The following is a description of a gene set: Electron transport chain Mouse Gene Set: WP_ELECTRON_TRANSPORT_CHAIN species: Mus musculus, and this is the list of marker genes: Uqcrq, mt-Co1, Cox6c (cytochrome c oxidase subunit 6C), Ndufb10, mt-Nd2, Ndufa6, Atp5f1c, mt-Atp8, Ndufb5, Ndufa9, Sdha, Ndufs1, Ndufa8, mt-Nd3, Uqcr10, Ucp1 (NCBI Gene Id 22227), Ndufs5, Ndufb3, mt-Nd4l, Ndufs7, Cox6a2, Atp5mf, Ndufs2, Atp5mc2, Atp5mc3, Ndufa7, Ndufv2, Uqcrc2, Cox5b, Ndufb9, Ndufb4c, Cox8a, mt-Co2, Cox6a1, Ndufb2, Uqcrc1 (NCBI Gene Id 66186), Ndufab1, Uqcrh, Atp5pb, Ndufc1, mt-Nd1, Cox7a2, Ndufs4, Slc25a27, mt-Atp6 (mitochondrially encoded ATP synthase 6), Ndufs8, Sdhd, Cox5a, Cox7a2l, Atp5pf, mt-Co3, Ucp2, Slc25a4, Atp5if1, Ndufa1, Cox4i1, Ndufa12, Surf1, Atp5po, Atp5f1b, Ndufa2, Ndufa10, Ndufs6, mt-Cytb, mt-Nd4, Cox7a1, Ucp3, Atp5f1e, Sdhb, Ndufa5, Sdhc, Ndufb7, Atp5f1a, Cox17, mt-Nd6, Ndufv1, Ndufb4, Ndufc2, Ndufb6, Sco1, Atp5mg, Cox15, Atp5pd, mt-Nd5, Uqcrfs1, Dmac2l, Ndufv3, Uqcr11, Slc25a5 (solute carrier family 25 (mitochondrial carrier, adenine nucleotide translocator), member 5), Uqcrb, Slc25a14, Atp5f1d, Cox7b